The following is a description of a gene set: species: Homo sapiens Human Gene Set: WP_MEVALONATE_PATHWAY Mevalonate pathway, and this is the list of marker genes: PMVK, HMGCS1, MVD, ACAT2, HMGCR, FDPS (farnesyl diphosphate synthase), MVK (NCBI Gene Id 4598)